Given this list of marker genes MARS1, GIMAP5, IL12A, MMEL1, MPV17, IL12RB1, SC5D, KIF12, MICOS13, CNOT1, DZIP1L, LYN, LYRM4, VPS33B, DEF6, UBR1, GPD1, SLC51B, LIPA, ABCB4, IFT56, BCS1L, GGT1, SLC51A, MYO5B, SEC63 (NCBI Gene Id 55399), AP1B1, INSR, DCDC2, LRP5, MRPL3, XK (NCBI Gene Id 7504), COG6, POU2AF1, SLC2A1, SLC25A13, IARS1, SPIB, SLC2A2, PEX2, ALMS1, TNFSF15 (NCBI Gene Id 9966), FCSK, SLC37A4, PKD2 (polycystin 2, transient receptor potential cation channel), TRMT10C, TNPO3, TREX1, IRF5, PRKCSH, PKHD1, here is a description of the gene set: Human Gene Set: HP_ABNORMAL_GAMMA_GLUTAMYLTRANSFERASE_LEVEL studied in species Homo sapiens Abnormal gamma-glutamyltransferase level Any deviation from the normal level of the enzyme gamma-glutamyltransferase (GGT). GGT is mainly present in kidney, liver, and pancreatic cells, but small amounts are present in other tissues.